The following is a description of a gene set: In normal development vascular endothelial growth factors (VEGFs) are crucial regulators of vascular development during embryogenesis (vasculogenesis) and blood-vessel formation in the adult (angiogenesis). In tumor progression, activation of VEGF pathways promotes tumor vascularization, facilitating tumor growth and metastasis. Abnormal VEGF function is also associated with inflammatory diseases including atherosclerosis, and hyperthyroidism. The members of the VEGF and VEGF-receptor protein families have distinct but overlapping ligand-receptor specificities, cell-type expression, and function. VEGF-receptor activation in turn regulates a network of signaling processes in the body that promote endothelial cell growth, migration and survival.<br>Molecular features of the VGF signaling cascades are outlined in the figure below (from Olsson et al. 2006; Nature Publishing Group). Tyrosine residues in the intracellular domains of VEGF receptors 1, 2,and 3 are indicated by dark blue boxes; residues susceptible to phosphorylation are numbered. A circled R indicates that phosphorylation is regulated by cell state (VEGFR2), by ligand binding (VEGFR1), or by heterodimerization (VEGFR3). Specific phosphorylation sites (boxed numbers) bind signaling molecules (dark blue ovals), whose interaction with other cytosolic signaling molecules (light blue ovals) leads to specific cellular (pale blue boxes) and tissue-level (pink boxes) responses in vivo. Signaling cascades whose molecular details are unclear are indicated by dashed arrows. DAG, diacylglycerol; EC, endothelial cell; eNOS, endothelial nitric oxide synthase; FAK, focal adhesion kinase; HPC, hematopoietic progenitor cell; HSP27, heat-shock protein-27; MAPK, mitogen-activated protein kinase; MEK, MAPK and ERK kinase; PI3K, phosphatidylinositol 3' kinase; PKC, protein kinase C; PLCgamma, phospholipase C-gamma; Shb, SH2 and beta-cells; TSAd, T-cell-specific adaptor.<br>In the current release, the first events in these cascades - the interactions between VEGF proteins and their receptors - are annotated. species: Homo sapiens part of: Signaling by Receptor Tyrosine Kinases Reactome Pathway: Signaling by VEGF, and this is the list of marker genes: PRKACA, SHB, NCKAP1L, ITGAV, PRKCD, WASF2, PGF, VEGFC, VAV1, AXL, NCF1, MAPK14, CYFIP1, HRAS, CDH5, PIK3R1, ACTB, NOS3, AKT1, NRAS, FLT4, CTNND1, PDPK1, PTK2, PAK2, CTNNB1, NCF2, ITGB3, MLST8, SPHK1, TRIB3, ELMO1, RHOA, THEM4, HSP90AA1, CDC42, NCK1, RICTOR, VAV2, MTOR, MAPK11, RAC1, KDR, PIK3R2, NRP2, SRC, CTNNA1, ITPR2, KRAS, NCK2, HSPB1, ELMO2, ROCK2, PIK3CA, CRK, VEGFA, MAPK13, CYBB, AAMP, NRP1, FLT1, ROCK1, RASA1, VAV3, ITPR1, AKT3, PRKACG, VEGFD, WASF1, AKT2, CAV1, JUP (NCBI Gene Id 3728), AHCYL1, MAPKAPK2, ACTG1, DOCK1, SH2D2A, SHC2, PAK3, MAPKAP1 (NCBI Gene Id 79182), PRR5, BRK1, MAPK12, N, M, ABI2, WASF3, VEGFB, CALM1, BCAR1, NCF4, PRKCZ, FYN, ITPR3, PRKACB (protein kinase cAMP-activated catalytic subunit beta), NCKAP1, PLCG1, MAPKAPK3, ABI1, CYBA, PAK1, PRKCA (NCBI Gene Id 5578), PTK2B, CYFIP2, PRKCB, PIK3CB, PXN, BAIAP2